Given this list of marker genes SHISA5, NEO1, SELENOW, NUDT5, USP18, ZNF35, IFITM3, FMNL3, P2RX4, KIF20A, PHKB, ATAD3A, TGM2, FBXO5, ITIH2, VIT, ANLN, VAMP5, THBD, VAMP3, SNURF, RAD9A, TOP2A, ABHD11, STAT1, PIR, ECT2, NUSAP1, MAPRE2, CCL5, IRF9, NQO2, NIT1, PLPP3, DHRS1, TIMM10, RBMX, LPAR6, S100A1, ID3, LGALS3BP, HOXB2, GALM, EXOC2, ADA, NACC1, BST2 (bone marrow stromal cell antigen 2), GBP2 (NCBI Gene Id 2634), CELF2, ENO2, EXOSC8, ID4, UBE2T, TRIM54, C4BPA, PTPRF, MMP3, SSPN, PLSCR1, ADAMTS1, CCND1, SNRPD1, THOC1, BID, SKAP2, RAMP2, CHRAC1, ALDH7A1, GRWD1, SDC4, WNT5A, PRRX1, BMI1, ISLR, LYPLAL1, PNP, CNMD, TMEM97, MRPL23, C4B, GPX7, SUB1, ZBP1, TOR3A, CPT1C, CRYZ, HELLS, KYAT3, GPAA1, KIF2C, DIAPH3, FOXP1, ILF2, HEXB, FUCA1, AGGF1, SESN3, AUP1, PPP1R3C, NDC80, UBQLN1, HSDL2, LGALS9, IFI35, AURKB, NEK2, KIF22, RBM12, FGF18, ESPL1, FXYD5, TCEAL1, IMPACT, GALT, TBX1, ORMDL1, ATM, ATP1B1, PRMT5, FOXA1 (NCBI Gene Id 3169, forkhead box A1), BLVRB, PALS2, RAD51, CTSH, SIGMAR1, OASL2P, CDC42SE1, B2M, DNAJC19, ABCB1, RNF128, GLA, RFX5, PPFIBP2, FOXP2, KHDRBS3, FOXC1, FABP7, POLA1, PFDN1, ABCG2, MELK, WNT5B, POLR2D, NFKB1, PAM, IGFBP2 (insulin like growth factor binding protein 2), FGF7, COL2A1, PAFAH2, CENPK, RFK, ZZZ3, MMACHC, HAUS1, ENO3, RNF113A, PON2, OSR1, XPO1, HNRNPR, PIP4P2, ASF1B, HOXA5, ARFGAP2, CDT1, CA13, SFRP4, MME, KRT32, ABCC4, VCAM1, LY96, STC2 (stanniocalcin 2), PYCR3, CDH11, BACE1, NUF2, MTREX, VEGFB, NPR3, PHLDA1, SLC41A2, ANG, TPX2, IFT20, IRGM, PLOD2, SLC12A2, PSMB8, ISG15, HDDC3, RCC2, NNMT, ADGRG2, TCIRG1, FABP4, PARP3, TUT4, KRT10, PCBD2, EYA1, BIRC5, PFN2, NAT8 (N-acetyltransferase 8 (putative)), IFI27L2, CDC25B, OSBPL3, LXN, LY6E, TNFRSF11B, SLC16A3, MFAP2, RTP4, SESN1, TPP1, PDPN, PHKA2, RSPO2 (R-spondin 2), ZNF322 (NCBI Gene Id 79692), DDAH1, ASNSD1, MRPL37, SMPDL3B, DTD1, GRK5, LRRC40 (NCBI Gene Id 55631), EIF1AY, RIPK3, PARP12 (poly(ADP-ribose) polymerase family member 12), PBK, GMNN, ARMCX2, HOXA2, RACGAP1, GNG11 (NCBI Gene Id 2791), FOXM1, SLC29A1, BICC1, NFIB, TRIM25, HLA-B, GRN, MT1X, IFI44, BCAT1, NRN1, CLTB, PDE1A, ATP10D, RNASE4, SLCO3A1, CD59, IFNGR1, TTK, LAMP2, GPX3 (NCBI Gene Id 2878), C1S, RAB28, S100A13, BAG1, GPRASP3, FOXD1, CXCL6, RAD1, CD14, TM4SF1, TRIM5, ALDH2, SOD3, GLCCI1, AKAP12, MFSD1, EMB, CAMK1, CDK8, TMEM47, PAX8, NSG1, PWP2, PON3, TINAGL1, CD302, APTX, CRYGS, CDC20, POLE, CR1L, PHPT1, NR2F1, FOXC2, MT1F, C1R, PGM1, IL13RA1, IRX3, F3, CENPH, PPP1R8 (protein phosphatase 1 regulatory subunit 8), SMARCA2, PNRC2, ID2, PRKCA, NAMPT, IFIT2, PTGR3, DNAJC15, TSPAN17, NDN, NDC1, LGALS8, KAZALD1, PSMB9, TSPAN6, RECK, DBP, IL1RN, FST, LTBP2, EGFL6, TACC3, POSTN (NCBI Gene Id 10631), CCN5, SCARB2, TMEM53, SASH1, C3, TOR1AIP1, PERP, SVEP1, UPF3B, DBF4 (NCBI Gene Id 10926), LBP, HAT1, SCARA3, CCNB1 (cyclin B1), TRIM32, HMMR, SNRPE, DLGAP5, RAP2A, TFPI, BHLHE40, PLK1, SRPX, CCNA2 (cyclin A2), THBS1, ACSL5, PFKL, CREG1, LCN2, ACADM, MGST1, CDO1, AIG1, CP, here is a description of the gene set: Genes up-regulated in MEF cells (embryonic fibroblast) with double knockout of the translation repressors 4EBP1 and 4EBP2. Transcriptional activation of cytokines, such as type-I interferons (interferon (IFN)-alpha and IFN-beta), constitutes the first line of antiviral defence. Here we show that translational control is critical for induction of type-I IFN production. In mouse embryonic fibroblasts lacking the translational repressors 4E-BP1 and 4E-BP2, the threshold for eliciting type-I IFN production is lowered. Consequently, replication of encephalomyocarditis virus, vesicular stomatitis virus, influenza virus and Sindbis virus is markedly suppressed. Furthermore, mice with both 4E- and 4E-BP2 genes (also known as Eif4ebp1 and Eif4ebp2, respectively) knocked out are resistant to vesicular stomatitis virus infection, and this correlates with an enhanced type-I IFN production in plasmacytoid dendritic cells and the expression of IFN-regulated genes in the lungs. The enhanced type-I IFN response in 4E-BP1-/- 4E-BP2-/- double knockout mouse embryonic fibroblasts is caused by upregulation of interferon regulatory factor 7 (Irf7) messenger RNA translation. These findings highlight the role of 4E-BPs as negative regulators of type-I IFN production, via translational repression of Irf7 mRNA. species: Mus musculus from publication Colina R, Costa-Mattioli M, Dowling RJ, Jaramillo M, Tai LH, Breitbach CJ, Martineau Y, Larsson O, Rong L, Svitkin YV, Makrigiannis AP, Bell JC, Sonenberg N (PMID 18272964) Human Gene Set: COLINA_TARGETS_OF_4EBP1_AND_4EBP2